The following is a description of a gene set: species: Mus musculus The action of a molecule that contributes to the structural integrity of a postsynapse. Mouse Gene Set: GOMF_STRUCTURAL_CONSTITUENT_OF_POSTSYNAPSE, and this is the list of marker genes: Mpp2, Ctnnd2, Septin7, Actb, Dbnl, Actn1, Homer1, Ina, Actg1, Shank1, Dlgap1, Acte1, Magi2, Dlg4, Dlg3, Dnm3, Nefl, Git1, Shank3 (SH3 and multiple ankyrin repeat domains 3), Dlg2, Nefh, Rapsn (NCBI Gene Id 19400), Dlg1, Camk2b, Sptbn2, Shank2, Actbl2, Actn2